Given this list of marker genes Hsp90ab1, Pla2g6, Prnp, Ddx39b, Nsf, Sae1, Myo5a, Myo9b, Dnajc5, Plk2, Stx1a, here is a description of the gene set: Binding to a protein or protein complex using energy from ATP hydrolysis. studied in species Mus musculus Mouse Gene Set: GOMF_ATP_DEPENDENT_PROTEIN_BINDING